Given this list of marker genes FER, CRISPLD1, PHC1, HIF1AN, SMR3B, CAMKV, GSTM2, ST3GAL1, MAP1B, CCDC136, SZT2, MTCL2, MAZ, ARF5, DCN, NALF2, PHYHIP, PM20D1 (peptidase M20 domain containing 1), CYRIB, KAAG1 (kidney associated DCDC2 antisense RNA 1), ABHD16A, WDR41, DOK1, SLC24A4, AKR1C1, TSPEAR, OIP5, ZNF346, SFMBT2, IFNAR2, REG4, SEPTIN8, FARSB, CTNND2, INKA2, CAMTA1, SHANK2, LDLRAD4, CS, NUCKS1, SLC39A3, UBE2W, ZNF618, NCS1, GUCA2A, ZKSCAN3, FIBCD1, CD47, CD320, CDC42BPB, EEF1A1, SNX1, DBNDD2, FAIM2, GPATCH2L, GATAD1, ENTPD1, KLC1, POM121, OPRM1, ZNF689 (NCBI Gene Id 553125), WBP1L, BAIAP2, NOS1, AP3B1, KIF21B, ZNF862, HROB, CIDEA, STON2, OLFML2A, CCL21, AHCYL2, SPEN (spen family transcriptional repressor), DAP, MEF2C, NCOR1, BBS1, SLC19A3, TRIM6-TRIM34, C6orf226, LPP, SUMF2, THEM5, URM1, LINC03043, PLXNA4, MGRN1, CACNA2D2, NCOA2, DSPP, SHH, RBM17 (NCBI Gene Id 84991), PISD, POM121C, TSPAN11, USP15 (NCBI Gene Id 9958), RELL1, ZNF710, HACD3 (3-hydroxyacyl-CoA dehydratase 3), UBE2R2, DDI1, FBXO11, FOXK1, SCRN2, SETD2, HPS4, ADAMTS6, PLCB2, RAB14, ACOT7, DOCK3, PCP4, GPR83, GALNT2, NFAT5, GAS7, PLXDC1, TRAF3, TAF5L, NF2, PPP1R1C, ATP11A, TRIM34, MAFB, DEK, DNAJC13, ZFAND3, FZD1, PTBP2, LHFPL1, EIF4H, TUBB8, DCAF7, PRM1, CPLX1, here is a description of the gene set: studied in species Homo sapiens Human Gene Set: MIR4722_5P from publication Chen Y, Wang X (PMID 31504780) Genes predicted to be targets of miRBase v22 microRNA hsa-miR-4722-5p in miRDB v6.0 with MirTarget v4 prediction scores > 80 (high confidence targets).